The following is a description of a gene set: studied in species Homo sapiens Human Gene Set: HP_ABNORMAL_LENGTH_OF_CORPUS_CALLOSUM Abnormal length of corpus callosum, and this is the list of marker genes: EIF4A2, PDHB, LSS, FOSL2, TAF8, ITGB6, AHSG, SLC35A2 (NCBI Gene Id 7355), SLC4A10, SNUPN